Given this list of marker genes BCL6, TRMT10A, YAE1, RBMX, TMC1, CDKL4, IL6ST, MLX, ZNF875, GPD1, ITPRID1, CNOT6, TEP1, CHD9, COLEC12, LRP3, LILRA1, CDIPT, FURIN, TMEM81, ICAM5, PFDN2, RSBN1, NUP93, ULBP1 (UL16 binding protein 1), CEACAM1, ARHGEF28, OST4, AASS, RESF1, KCNIP2, ETNK2, SEC14L5, TGS1, CD86 (CD86 molecule), PTAR1, SPRED3, SPPL2C, EPHA5 (NCBI Gene Id 7304), ANAPC10 (NCBI Gene Id 25866), ZBTB22, PYGO2, PCLAF, SLC38A4, KIF3C, PHC3, PPP1R1B, MTUS2, PHF20, ZNF239, NDUFAF3, BLID, SLC23A2, ATRNL1, CBX5, MYO10, AKR1B1, MSRB2, ZNF124, SMARCA2, SLC41A1, SLC26A7, BTG2, ARL5A, FAM78A, here is a description of the gene set: from publication Chen Y, Wang X (PMID 31504780) Human Gene Set: MIR197_5P studied in species Homo sapiens Genes predicted to be targets of miRBase v22 microRNA hsa-miR-197-5p in miRDB v6.0 with MirTarget v4 prediction scores > 80 (high confidence targets).